Given this list of marker genes NR4A1, CERK, NAPSB, MRI1, ZBED1 (NCBI Gene Id 9189), FAM53B, RPH3A, RNF44, PIGS, DCTN3, AOC1, APBB1IP, MRPS34, SVBP, MIF4GD, ANXA6, ASGR2, CDK5RAP3, WDFY2, CMTM7, ITGA4, NXT1, XPA, PEBP1, TATDN2, UQCR11, STX16, HDHD5, L3MBTL3, CIDEB, SARAF, MFNG, NFATC2IP, AGO1, AIFM3, APEX1, TMEM170B, WDR54, TMEM39B, CORO2A, KLF2, PADI4, MYC, SLC2A4RG, TAPT1, SLC46A2, GRK3, CIAO2A, ZNF395, HDDC3, NRGN, MYO7A (myosin VIIA), CAPNS1, S100P, LINC00939, ANAPC15, PPT1, ALDH1A1, CHP1, BEX5, PCIF1, NSD3, ZNF362, RASGEF1A, TESC, MPPE1, MIB2, EPRS1, AMT, AKR7A2, OGFOD3, MZT2A, PTPN22, SNRPA, SF3A1, GAS7, ABCA7, ARPIN, LRRCC1, ARF5, WBP11, TRAPPC1, ZNF652, LRP5L, ASGR1, CHRAC1, S1PR3, ALDH3B1, CNOT8, COQ8A, SAT2, FBXO42, RBL2, ZBED10P, PRPF31, WDR18 (WD repeat domain 18), P2RY8, MTCP1, EGR1, LRPAP1, AKT1, JMY, MAN1B1, NUDT1, FAM120C, SIN3B, BACE1, REPS2, ERICH1, P2RY13, SLC66A3, NME3, UQCRFS1 (ubiquinol-cytochrome c reductase, Rieske iron-sulfur polypeptide 1), CLEC4G, FAM210B, THYN1, MBOAT1, CLSTN1, LAMTOR1, LINC00528, GPD1L, KLHDC2, ANAPC5, PADI2, NREP, TBCD, GGACT, CRIP1, ANKRD50, ARHGEF9, SLC25A45, ZCCHC24, YPEL2, TMEM183A, CCDC43, SUMF2, VEGFA, SMARCC2, GSTM4, PRKACA, CDC40, RPIA, NDRG3, CHPT1, SLC18B1, SLC25A29, SNX17, FCGRT, ADD3, F5, TBC1D14 (TBC1 domain family member 14), MAPRE2, RNASE2, CRISPLD2, SLC46A3, ESYT1, ASF1B, TLE3, SPATA6, RNF130, TRAM2, TNRC6B, ATPAF2 (ATP synthase mitochondrial F1 complex assembly factor 2), VAMP8, REX1BD, SRRM1, RERE, ALAD, CDK5, PSTPIP1, RAB4A, INPP5K, EIF3H, PIK3R1, SGSM3, NRIP1, HERC2, BZW2, COPS3, TKT, TMT1A, MSRB2, AKAP8, CYSLTR1, PTP4A1, IGFBP7, KIF22, KLF7, TMEM14C, TXNDC11, RAB3D, ASB13, TMEM65, TMEM219, SNTB1, TBC1D4, LST1, CCDC13-AS2, here is a description of the gene set: Th1 and Th2 cells arise from a common precursor cell in response to triggering through the TCR and cytokine receptors for IL-12 or IL-4. This leads to activation of complex signaling pathways, which are not known in detail. Disturbances in the balance between type 1 and type 2 responses can lead to certain immune-mediated diseases. Thus, it is important to understand how Th1 and Th2 cells are generated. To clarify the mechanisms as to how IL-12 and IL-4 induce Th1 and Th2 differentiation and how TGF-beta can inhibit this process, we have used oligonucleotide arrays to examine the early polarization of Th1 and Th2 cells in the presence and absence of TGF-beta after 0, 2, 6 and 48 hours of polarization. Human Gene Set: GSE2770_TGFB_AND_IL4_VS_IL4_TREATED_ACT_CD4_TCELL_48H_DN species: Homo sapiens Genes down-regulated in CD4 T cells activated by anti-CD3 and anti-CD28: TGFB1 and IL4 (48h) versus IL4 (48h). from publication Lund R, Aittokallio T, Nevalainen O, Lahesmaa R (PMID 14607935)